Given this list of marker genes Sumo1 (NCBI Gene Id 22218), here is a description of the gene set: electronically inferred by orthology from the curated human pathway Reactome Pathway: SUMO is conjugated to E1 (UBA2:SAE1) This event has been computationally inferred from an event that has been demonstrated in another species.<p>The inference is based on the homology mapping from PANTHER. Briefly, reactions for which all involved PhysicalEntities (in input, output and catalyst) have a mapped orthologue/paralogue (for complexes at least 75% of components must have a mapping) are inferred to the other species. studied in species Mus musculus part of: Processing and activation of SUMO